The following is a description of a gene set: Human Gene Set: REACTOME_CHK1_CHK2_CDS1_MEDIATED_INACTIVATION_OF_CYCLIN_B_CDK1_COMPLEX Chk1/Chk2(Cds1) mediated inactivation of Cyclin B:Cdk1 complex studied in species Homo sapiens, and this is the list of marker genes: YWHAH, CCNA1, CCNA2, CDC25C, YWHAE, YWHAG, YWHAQ, CHEK2, SFN, CCNB1, CHEK1, WEE1, CDK1, YWHAZ, YWHAB